The following is a description of a gene set: studied in species Mus musculus An arrangement of closely apposed microtubules running parallel to each other. Mouse Gene Set: GOCC_MICROTUBULE_BUNDLE, and this is the list of marker genes: Tppp3, Numa1, Tppp, Mark2, Atat1, Mtcl1